Given this list of marker genes SPP1, TYMP, PTK2, VEGFA, EDN1, ITGAV, EZH2, E2F3, STC1, CXCR4 (NCBI Gene Id 93405), VCAN, FGF18, CD44, FGFR1, FYN, NOTCH1, JAG1, VAV2, TNFAIP6, MMP9, CCND2, JAG2, HEY1, CCNE1, PDGFA, here is a description of the gene set: Human Gene Set: LU_TUMOR_ANGIOGENESIS_UP from publication Lu C, Bonome T, Li Y, Kamat AA, Han LY, Schmandt R, Coleman RL, Gershenson DM, Jaffe RB, Birrer MJ, Sood AK (PMID 17308118) studied in species Homo sapiens Therapeutic strategies based on antiangiogenic approaches are beginning to show great promise in clinical studies. However, full realization of these approaches requires identification of key differences in gene expression between endothelial cells from tumors versus their normal counterparts. Here, we examined gene expression differences in purified endothelial cells from 10 invasive epithelial ovarian cancers and 5 normal ovaries using Affymetrix U133 Plus 2.0 microarrays. More than 400 differentially expressed genes were identified in tumor-associated endothelial cells. We selected and validated genes that were overexpressed by 3.6- to 168-fold using real-time reverse transcription-PCR and/or immunohistochemistry. Among these, the polycomb group protein enhancer of Zeste homologue 2 (EZH2), the Notch ligand Jagged1, and PTK2 were elevated 3- to 4.3-fold in tumor-associated endothelial cells. Silencing these genes individually with small interfering RNA blocked endothelial cell migration and tube formation in vitro. The present study shows that tumor and normal endothelium differ at the molecular level, which may have significant implications for the development of antiangiogenic therapies. Up-regulated genes of putative pathways stimulated in tumor endothelial cells by papillary serous ovarian epithelial tumor cells.